Given this list of marker genes PPM1A, NAA60, NAA80 (NCBI Gene Id 24142), NTMT1, NAA10, NAA15 (NCBI Gene Id 80155), PPM1B, NAA11, CREBBP, NMT2 (NCBI Gene Id 9397), NTMT2, NMT1, KAT2B, AANAT, NAA16, EP300, NAA20, HHATL, NAA50, HHAT, here is a description of the gene set: Human Gene Set: GOBP_N_TERMINAL_PROTEIN_AMINO_ACID_MODIFICATION species: Homo sapiens The alteration of the N-terminal amino acid residue in a protein.